Given this list of marker genes SLC6A6, SLC32A1, SLC6A13, NHERF1, SLC7A14, SLC6A1, here is a description of the gene set: Human Gene Set: GOBP_GAMMA_AMINOBUTYRIC_ACID_IMPORT The directed movement of gamma-aminobutyric acid (GABA, 4-aminobutyrate) into a cell or organelle. species: Homo sapiens